The following is a description of a gene set: Human Gene Set: GOMF_MISFOLDED_PROTEIN_BINDING species: Homo sapiens Binding to a misfolded protein., and this is the list of marker genes: TOR1A, LONRF2, F12, SDF2L1, DNAJB9, HDAC6, SDF2, DNAJC10, EIF2AK3, HSPA1A, CLU, STUB1 (STIP1 homology and U-box containing protein 1), HSPA5, EDEM1, CLUL1, DNAJB11, DNAJC3, BAG6